Given this list of marker genes CHMP1A, COX4I1, KIAA0513, ANKRD11, FBXO31, GALNS, USP10, ZCCHC14, MBTPS1, TCF25 (NCBI Gene Id 22980), SLC7A5, APRT, TRAPPC2L, EMC8, ZDHHC7, MAP1LC3B, SPG7, MEAK7, here is a description of the gene set: In addition to RB1 gene mutations, retinoblastomas frequently show gains of 1q and 6p and losses of 16q. To identify suppressor genes on 16q, we analyzed 22 short tandem repeat loci in 58 patients with known RB1 mutations. A subset of tumors was also investigated by conventional and matrix comparative genomic hybridization. In 40 of 58 (69%) tumors, we found no loss of heterozygosity (LOH) at any 16q marker. LOH was detected in 18 of 58 (31%) tumors, including five with allelic imbalance at some markers. In one tumor LOH was only observed at 16q24. As the parental origin of allele loss was unbiased, an imprinted locus is unlikely to be involved. Analysis of gene expression by microarray hybridization and quantitative RT real-time PCR did not identify a candidate suppressor in 16q24. Cadherin 13 (CDH13), CBFA2T3, and WFDC1, which are candidate suppressors in other tumor entities with 16q24 loss, did not show loss of expression. In addition, mutation and methylation analysis showed no somatic alteration of CDH13. Results in all tumors with chromosome 16 alterations define a single minimal deleted region of 5.7 Mb in the telomeric part of 16q24 with the centromeric boundary defined by retention of heterozygosity for a single nucleotide variant in exon 10 of CDH13 (Mb 82.7). Interestingly, clinical presentation of tumors with and without 16q alterations was distinct. Specifically, almost all retinoblastomas with 16q24 loss showed diffuse intraocular seeding. This suggests that genetic alterations in the minimal deleted region are associated with impaired cell-to-cell adhesion. Genes from 16q24 region up-regulated in retinoblastoma tumors with 16q24 LOH (loss of heterozygocity) compared to those without the LOH. studied in species Homo sapiens from publication Gratias S, Rieder H, Ullmann R, Klein-Hitpass L, Schneider S, Bölöni R, Kappler M, Lohmann DR (PMID 17210724) Human Gene Set: GRATIAS_RETINOBLASTOMA_16Q24